Given this list of marker genes Abcd4, Dhx36, Magel2 (MAGE family member L2), Stil, Naa15, Tes, Akap8, Cd2bp2, Luc7l2 (LUC7-like 2 (S. cerevisiae)), Ext1, Lifr, Arsa, Rest, Nnat, Eny2, Ptpn1, Gng3, Cd59b, Kdm6a, Wdr26, Pou2f1, Bpnt2, Satb1, Erf, Aktip, Bmp4, Efna3, Sp1, Igf1r, Agfg1 (NCBI Gene Id 98611), Glg1, Atp6v1a, Enpp5, Zfp322a, Mtf2, Urm1 (NCBI Gene Id 68205), Hoxd1, Grik5, Pten, Sfrp2, Srsf7, Spg21, Diaph2, Pcgf2, Akap12, Atxn2, Tbl1x, Slc6a6, Klf7, Ndn, Fbln2, Pura, Vegfa, Fgd1, Islr, Cic, Cmtm6, Mark2, Calm3, Wwtr1, Ube3a, Pgf, Nrp1, Rragd, Smarcc1, Tbx3, Efna2, Ptpn13, Rtn1, Fzd4, Wwc2, Elovl6, Iqgap1, Pcm1, Sox11, Epha4, Zfhx3, here is a description of the gene set: from publication Guo Y, Chan R, Ramsey H, Li W, Xie X, Shelley WC, Martinez-Barbera JP, Bort B, Zaret K, Yoder M, Hromas R (PMID 12791650) Genes up-regulated in day 6 embryoid bodies derived from embryonic stem cells (ES) with HEX knockout. species: Mus musculus The first hematopoietic and endothelial progenitors are derived from a common embryonic precursor termed the hemangioblast. The genetic cascades that regulate the differentiation of the hemangioblast to hematopoietic and endothelial cells are largely unknown. In general, much of embryonic development is coordinately regulated by temporal and spatial expression of transcription factors, such as the Homeobox (Hox) gene family. We and others isolated a divergent homeobox gene termed Hex (or Prh) that is preferentially expressed in hematopoietic and endothelial cells. Using in vitro Hex-/- embryonic stem (ES) cell differentiation, in vivo yolk sac hematopoietic progenitor assays, and chimeric mouse analysis, we found that Hex is required for differentiation of the hemangioblast to definitive embryonic hematopoietic progenitors and to a lesser extent endothelial cells. Therefore, Hex is a novel regulator of hemangioblast differentiation to hematopoietic and endothelial cells. Mouse Gene Set: GUO_HEX_TARGETS_UP